The following is a description of a gene set: species: Homo sapiens Genes predicted to be targets of miRBase v22 microRNA hsa-miR-6861-5p in miRDB v6.0 with MirTarget v4 prediction scores > 80 (high confidence targets). Human Gene Set: MIR6861_5P from publication Chen Y, Wang X (PMID 31504780), and this is the list of marker genes: TMED5, SMARCA2, CREB3L3, SMTNL2, TPPP3, SLC5A9, SYNGR2, NAIF1, TBC1D7, CLCN5, TARDBP, MBNL1, MID1, SP1, MARCKS, ZCCHC12, PROSER3, COLEC11, MED28, RPN2, HDGF, MYORG, LPP, NLK, LACC1, GIPC3, L1TD1, PEG10, CDC42SE2, CHD1L, EML2 (EMAP like 2), KCTD11, SP140, AVIL, C1orf87, VCF1, ZBTB18, SLC26A3, EVI2B, PDE3A, PPP1R3F, PURB, TNFRSF11A, GPR15 (G protein-coupled receptor 15), FCGR3B, LZTS2, FCGR3A, NDUFA10, DMP1, RB1CC1, SNX2 (sorting nexin 2), ELOVL2 (NCBI Gene Id 54898), AZIN1, RILPL1, MOB3C, CC2D2A, DARS2, AGBL2, SLC2A10, DBF4B, SASH1, PLEKHS1, ANKRD12, NEDD1, ZFP3, TREM1, INHBA, S100Z